Given this list of marker genes CD5L, APOA1, PRDX1 (NCBI Gene Id 5052), SAA1 (serum amyloid A1), SSC5D, HMGB1, APOB, SCARB1, CD36, S100A9, here is a description of the gene set: part of: Binding and Uptake of Ligands by Scavenger Receptors Reactome Pathway: Scavenging by Class B Receptors studied in species Homo sapiens Class B receptors have two transmembrane domains separated by an extracellular loop.